The following is a description of a gene set: Human Gene Set: GOBP_ANTEROGRADE_NEURONAL_DENSE_CORE_VESICLE_TRANSPORT species: Homo sapiens The directed movement of substances in neuronal dense core vesicles along axonal microtubules towards the presynapse., and this is the list of marker genes: MAP2, SYBU, TRIM46, KIF1A, KIF5B, KIF1C